Given this list of marker genes Mylip (myosin regulatory light chain interacting protein), Git1, Pcsk9, Laptm5 (NCBI Gene Id 16792), Hamp (NCBI Gene Id 84506), Dtx3l, Mtmr2, Furin, Hamp2, Apoe, Itch, Anxa2, Ptpn1, Abca2, here is a description of the gene set: Mouse Gene Set: GOBP_REGULATION_OF_RECEPTOR_CATABOLIC_PROCESS species: Mus musculus Any process that modulates the frequency, rate or extent of receptor catabolic process.